The following is a description of a gene set: Mouse Gene Set: GOCC_SERINE_TYPE_PEPTIDASE_COMPLEX species: Mus musculus A protein complex which is capable of serine-type peptidase activity., and this is the list of marker genes: Spcs2, Arxes2, Mbl2, Plaur, F3, Spcs1, Immp2l, Plau, Thbd, Immp1l, Sec11c, Htra2, F7, Arxes1, Cfh, Spcs3, Fcnb, Cfhr4, Sec11a